Given this list of marker genes GP1BB, FLNA, GP1BA, JAK2, SVEP1, PLEK (NCBI Gene Id 5341), PEAR1, SELP, PTPRJ (NCBI Gene Id 5795), TLR4, GP9 (glycoprotein IX platelet), GP5, PLA2G4A, here is a description of the gene set: Any process that increases the rate or frequency of platelet activation. Platelet activation is a series of progressive, overlapping events triggered by exposure of the platelets to subendothelial tissue. studied in species Homo sapiens Human Gene Set: GOBP_POSITIVE_REGULATION_OF_PLATELET_ACTIVATION